Given this list of marker genes Bace2 (NCBI Gene Id 68803), Ap3s1, Hps5, Myo5a, Ap1m1, Rab11b, Apoe, Bloc1s4, Kif13a, Bloc1s2, Mlph, Shroom2, Rab32, Hps1, Vps33a, Rab17, Bloc1s1 (biogenesis of lysosomal organelles complex-1, subunit 1), Ap1b1, Hps4, Hps3, Abcb6, Bloc1s3, Hps6, Rab11a, Ankrd27, Cd63, Rab38, Myo7a, Mreg, Pmel, Ap1s3 (NCBI Gene Id 252903), Ap3d1, Dctn2 (NCBI Gene Id 97666), Map2k1, Ap3m1, Lyst, Shroom3, Snapin, Tyrp1, Ap1s2, Bloc1s6, a, Rab1a, Pomc, Rab27a, Gpr143, Bloc1s5, Dtnbp1, Ap1g1, Dctn1, Pikfyve, Zeb2, Vps33b (NCBI Gene Id 233405), Cdh3, Ap3b1, Rab29, Ap3s2, Ap1s1, Bcl2, here is a description of the gene set: Mouse Gene Set: GOBP_CELLULAR_PIGMENTATION The deposition or aggregation of coloring matter in a cell. studied in species Mus musculus